Given this list of marker genes PLCB2, ITPR1, MCU, SLC25A31, PLCB3, CASP7, GNAQ, ITPR2, PLCB1, PLCB4, APAF1, VDAC3, SLC25A6, VDAC2, HTT, CASP3, SLC25A4, CASP9, ITPR3, VDAC1, CYCS, SLC25A5, GRM5, here is a description of the gene set: Pathway Definition from KEGG: Glutamate -> GRM5 -> GNAQ -> PLCB -> IP3 -> (ITPR+HTT*) -> Ca2+ -- MCU -> Ca2+(mito) -- MPTP -> CYCS == APAF1 -> CASP9 -> (CASP3,CASP7) Mutation-caused aberrant Htt to mGluR5-Ca2+ -apoptotic pathway. Pathway ID: N00985. Pathway type: Variant. Pathway class: nt06461 Huntington disease. Human Gene Set: KEGG_MEDICUS_VARIANT_MUTATION_CAUSED_ABERRANT_HTT_TO_MGLUR5_CA2_APOPTOTIC_PATHWAY species: Homo sapiens